Given this list of marker genes Map3k4, Bmp4, Met, Dlg1, Dsc2, Hand2, Zc3h12a, Dusp1, Phlpp1, Mfhas1, Trem2, Gdf6, Gadd45b, Dusp10, Oprk1, Ezr, Sash1, Map3k5, Map3k3, Sphk1, Gadd45g, Cyld, Xdh, Lep, Ccr2, Vegfa, Rell2, Dab2ip, Dsg3, Ptpn22, Il1b, Gadd45a, Spi1, Cav3, Ager, Kcnn4, Bmp2, Hgf, Mink1, Stk39, Rell1, Trpv4, Ulk4, Pja2, Gsn, Per1, here is a description of the gene set: Any process that modulates the frequency, rate or extent of p38MAPK cascade. Mouse Gene Set: GOBP_REGULATION_OF_P38MAPK_CASCADE species: Mus musculus